Given this list of marker genes Cxcl1, Ccl7, Klf6, Ccl21a, Cxcl13, Cxcl5, Iigp1, Ccl5, Ccl2, Cxcl2, Ccl9 (NCBI Gene Id 20308), Csf2rb2, Pirb, here is a description of the gene set: from publication Soucek L, Lawlor ER, Soto D, Shchors K, Swigart LB, Evan GI (PMID 17906636) Chemokine genes up-regulated within 2 hr of c-Myc activation in a mouse model of Myc-induced pancreatic beta-cell tumorigenesis. Mouse Gene Set: SOUCEK_MYC_TARGETS species: Mus musculus An association between inflammation and cancer has long been recognized, but the cause and effect relationship linking the two remains unclear. Myc is a pleiotropic transcription factor that is overexpressed in many human cancers and instructs many extracellular aspects of the tumor tissue phenotype, including remodeling of tumor stroma and angiogenesis. Here we show in a beta-cell tumor model that activation of Myc in vivo triggers rapid recruitment of mast cells to the tumor site-a recruitment that is absolutely required for macroscopic tumor expansion. In addition, treatment of established beta-cell tumors with a mast cell inhibitor rapidly triggers hypoxia and cell death of tumor and endothelial cells. Inhibitors of mast cell function may therefore prove therapeutically useful in restraining expansion and survival of pancreatic and other cancers.